The following is a description of a gene set: Propensity for subsequent distant metastasis in head and neck squamous-cell carcinoma (HNSCC) was analysed using 186 primary tumours from patients initially treated by surgery that developed (M) or did not develop (NM) metastases as the first recurrent event. Transcriptome (Affymetrix HGU133_Plus2, QRT-PCR) and array-comparative genomic hybridization data were collected. Non-supervised hierarchical clustering based on Affymetrix data distinguished tumours differing in pathological differentiation, and identified associated functional changes. Propensity for metastasis was not associated with these subgroups. Using QRT-PCR data we identified a four-gene model (PSMD10, HSD17B12, FLOT2 and KRT17) that predicts M/NM status with 77% success in a separate 79-sample validation group of HNSCC samples. This prediction is independent of clinical criteria (age, lymph node status, stage, differentiation and localization). The most significantly altered transcripts in M versus NM were significantly associated to metastasis-related functions, including adhesion, mobility and cell survival. Several genomic modifications were significantly associated with M/NM status (most notably gains at 4q11-22 and Xq12-28; losses at 11q14-24 and 17q11 losses) and partly linked to transcription modifications. This work yields a basis for the development of prognostic molecular signatures, markers and therapeutic targets for HNSCC metastasis. studied in species Homo sapiens from publication Rickman DS, Millon R, De Reynies A, Thomas E, Wasylyk C, Muller D, Abecassis J, Wasylyk B (PMID 18679425) Cluster f: genes identifying an intrinsic group in head and neck squamous cell carcinoma (HNSCC). Human Gene Set: RICKMAN_HEAD_AND_NECK_CANCER_F, and this is the list of marker genes: TNNI1, MB, ANK2, TPM1, MYH2, CST1, TNNC1, EEF1A2, DDIT4L, ACTA1, CMYA5, TNNC2, CSRP3, MYBPC1, XIRP2, FHL1, TNNI2 (troponin I2, fast skeletal type), PTGIS, STIMATE, TPM3, ACTC1, NEB, KLHL41 (NCBI Gene Id 10324), DES, ZFPM2, TTN, MYL1, KLHDC7B, PDK4, ACTN2, SLN, DCLK1, NEXN, PLA2G2A, HSPB3, MYOT, THBS4, CKM, ANKRD39, CYP1B1, MYBPC2, MYL11, CHGB, IGF1, SYNPO2, CASQ2, SMPX, CHRDL1, MYH1, TPM2, APOD, ENO3, ABCA8, PKIA, MYL2